Given this list of marker genes ZP2, ZP1, CD9, PIGA, CD81, ZP3, BSG, PLCB1, here is a description of the gene set: Reproduction is required for the survival of all mammalian species, and thousands of essential 'sex' genes are conserved through evolution. Basic research helps to define these genes and the mechanisms responsible for the development, function and regulation of the male and female reproductive systems. However, many infertile couples continue to be labeled with the diagnosis of idiopathic infertility or given descriptive diagnoses that do not provide a cause for their defect. For other individuals with a known etiology, effective cures are lacking, although their infertility is often bypassed with assisted reproductive technologies (ART), some accompanied by safety or ethical concerns. Certainly, progress in the field of reproduction has been realized in the twenty-first century with advances in the understanding of the regulation of fertility, with the production of over 400 mutant mouse models with a reproductive phenotype and with the promise of regenerative gonadal stem cells. Indeed, the past six years have witnessed a virtual explosion in the identification of gene mutations or polymorphisms that cause or are linked to human infertility. Translation of these findings to the clinic remains slow, however, as do new methods to diagnose and treat infertile couples. Additionally, new approaches to contraception remain elusive. Nevertheless, the basic and clinical advances in the understanding of the molecular controls of reproduction are impressive and will ultimately improve patient care. Genes important for fertilization, based on mouse models with female fertility defects. from publication Matzuk MM, Lamb DJ (PMID 18989307) Human Gene Set: MATZUK_FERTILIZATION species: Homo sapiens